The following is a description of a gene set: Human Gene Set: HP_ELEVATED_CIRCULATING_ALDOLASE_CONCENTRATION Elevated circulating aldolase concentration studied in species Homo sapiens Concentration of fructose 1,6-bisphosphate aldolase in the blood circulation above the upper limit of normal., and this is the list of marker genes: DPYS, LPIN1, HSPG2, OBSCN, MT-CO1, PFKM, MT-CO3, TGFB1, TANGO2